Given this list of marker genes NDUFB2, PCDHGB6, EMC3, BST1, PTX3, LMBRD1, HARS2, NDRG2, JUP, DHRS7, HBP1, TBX3, TUBB2A, AP1G1, FOLR2, PRDX6, MIP, KCNQ1, ZNF804A, SMYD3, KATNBL1, AMIGO2, WDR7, EPN2, SIL1, ASAH1, ZNF135, LRRC8D, DUSP22, CRTAP, MARCHF3, TIE1, GRB10, FMO5, RMND5A, RTN2, TMOD1, TIMP3 (TIMP metallopeptidase inhibitor 3), DCAF6, TBXAS1, CLCN3, HERC1 (HECT and RLD domain containing E3 ubiquitin protein ligase family member 1), ANKRD27, NPVF, DNAJB9, CLIC4, RCBTB2, CAMLG (calcium modulating ligand), UBE2D4, DUSP10, SUPT20H, ZFAND1, FAM168B, F13A1, RP2, SCGB1D2, MCFD2, EVPL, ADM, VPS53, RIN1, RHEB, LPGAT1, EFS, SERINC3, DOCK6, ZBTB20, TMEM87A, ADGRE3, XPNPEP1, CLCN7, PAPSS1, EXTL2, TSPAN6, HRH3, ABI3BP, CD36, ZKSCAN3, DAB2, SORBS1, LYZ, TMEM268, GABRA1, LAPTM4A, PPCS, EEF1AKMT3, BET1, CYB5R1, KIAA1549L, APMAP, FBXO38, IGFLR1, TPM1, LILRA3, FRAT1, GNS, GSAP, PMEPA1, CLK1, PEX11B, HEXA, RHOBTB3, PLEKHG3, SIGLEC5, SST, TTC19, ZMYND8, GALC, COL13A1, KIDINS220 (kinase D interacting substrate 220), NR0B1, SLFN12, ZNF516, CCDC68, R3HDM2, MTFR1, GNAI1, TRAPPC2, MYH7B, TSPAN3, SPRY2, GLUL, TMEM127, GALNT3, HEY1, FAIM2, ZDHHC7, CTNND1, FCGR2C, CD300A, KLC1, SLC48A1, RGS19 (NCBI Gene Id 10287), INHBB, MID1, ZFYVE9, ITM2B, BLVRA, GSTT2, COPZ2, BASP1, ZNF175, GMPR, CETN2, CPVL, GSR, HP, SAMSN1, CRLF2, BMAL1, YIPF1, BLK, ANXA1 (NCBI Gene Id 301), SOCS5, SPI1, SH3GLB1, NPR3, TMEM185B, LPIN1, CAMTA1, IL1RN, GALNT1, LCMT1, LYZL6, DPY19L1, FBP1, CAST, ZCCHC24, NRP1, MKRN1, EMCN, TGFBR2, SMIM7, SLC10A3, AP5M1, FCGR3B, SECISBP2, MEIS2, FLNB, FAM171A1, SMPDL3A, CHST15, ELK4, PHYH, PTK2 (protein tyrosine kinase 2), ATP6V1H, BNC2, BID, RREB1, DSTN, KIAA0232, FAT1, AFF1, VCL, PLEKHF2, SHBG, TPP1 (NCBI Gene Id 727719), PCOLCE2, here is a description of the gene set: Human Gene Set: GSE3982_MAST_CELL_VS_TH2_UP In the present study we used Affymetrix oligonucleotide microarrays to produce gene transcription profiles for the major leukocyte types in humans. This comprehensive dataset enabled us to not only establish which genes were expressed in each leukocyte type, but also which genes were expressed in each subset after activation. The used of a comprehensive dataset of gene profiles from all the major human leukocyte subsets enabled a novel and powerful means for identification of genes associated with single leukocyte subsets, or different immune paradigms. from publication Jeffrey KL, Brummer T, Rolph MS, Liu SM, Callejas NA, Grumont RJ, Gillieron C, Mackay F, Grey S, Camps M, Rommel C, Gerondakis SD, Mackay CR (PMID 16474395) species: Homo sapiens Genes up-regulated in comparison of mast cells versus Th2 cells.